The following is a description of a gene set: Human Gene Set: MIR6842_5P Genes predicted to be targets of miRBase v22 microRNA hsa-miR-6842-5p in miRDB v6.0 with MirTarget v4 prediction scores > 80 (high confidence targets). from publication Chen Y, Wang X (PMID 31504780) studied in species Homo sapiens, and this is the list of marker genes: SPRED3, CELF5, RUNX3, PDF, PTPRD, MSR1, COG8, PABPC1L2B, ZBTB7A, GSDMA, CAMK2A, KCNK3, PCYT1B, CYP2W1, LHFPL1, PRKACA, OLFM2, DESI1 (desumoylating isopeptidase 1), VPS13D, CDK12, CETN1, CABP2, ZFR2, KDM6B, HIP1, MIER2, ARID3B, RRP7A, MYH14, SEPTIN9, TBKBP1, DOK3, DDAH1, WDR33 (WD repeat domain 33), RAB18, ZNF512B, ATL2, SYNGAP1, SPNS2, SLC8A2, RC3H1, GPR3 (G protein-coupled receptor 3), RAB3A (RAB3A, member RAS oncogene family), GGA1, DNAJB5, NECTIN1, PSD4, LIN7C, FOSL1, RAB1B, DAGLA, HECTD3 (NCBI Gene Id 79654), DMTN, IQSEC2, MNT, YWHAH, CREB3L1, TPBGL, NFIC, P2RX1, RSPO4, SLC25A4 (NCBI Gene Id 7872, solute carrier family 25 member 4), TRIM3, ZC3H7B, THEMIS2, TMEM51, ADGRB1, UPK2, CDK5R2, PRKCG, BCL11B, TNS4, SLC6A17, ZNF74, MEF2D, ZNF324, CITED2, IGFBP5, NDFIP1, C5AR1, SCRT2, PABPC1L2A, BANF1, EGFR, CYB5R3, SEMA6A, HYOU1, EFNA5, BCL2L13, PADI2, RALY, MECP2, SMARCD1, CD276 (CD276 molecule), GRIN3A, TRIM58, FOXO6, ARHGEF1, NECTIN4, TLDC2, RPP14, TTC9, SYT5, FOXA2, FIZ1, PTGES2, ASIC1, OTUB1, KLC2, CNIH2, CNPY2, TOR1A, PPP6R1, CNIH4, KLF12, U2AF1L4, LZTS3, DMPK, PIP5K1A, LEF1, FXR2, PHOSPHO1, RASL10B, CDC25A, SFTPB, RARA, RAB2A, ABLIM3, NEURL1B, TBC1D30, PIN1, CNNM1, PLVAP, ZNF385A, CTCFL, IGF2, POLR2F, KCNIP3, HSD11B2, B3GNT7 (UDP-GlcNAc:betaGal beta-1,3-N-acetylglucosaminyltransferase 7), STRADA, ZSWIM4 (NCBI Gene Id 65249), DPY19L1, FOXP4, NTSR1 (NCBI Gene Id 4923), PTCH1, HOXA9, TRH, PUS10 (NCBI Gene Id 150962), FZD2 (frizzled class receptor 2), B4GALT7, KMT5A, EFNB1, DLK1, KMT2D